Given this list of marker genes ATPAF2, TSPAN3, HLA-DPB1, ZSCAN32, RHOB, OPN3, COQ2, USP22, SHMT2, HSP90B1, FBXW11, LMO2, CAT, CD200, TULP2, PDE7B, SPIB, S100A8, TBC1D9, TSHR, COBLL1, RAB31, TBC1D22A, FTSJ1, MKLN1, ZDHHC4, NT5E, SYPL1, SCRN1, CNP, MICALL1, FCGR2C, METTL25B, CLEC4A, IGKC, RASGRP3, ISG20, IGHM, LAMP5, HPS5, PIP5K1B, ARMCX2, CTSH, ZNF804A (NCBI Gene Id 91752), PSMD10, GSTZ1, SAV1, MS4A1, ATP10D, NUMB, HLA-DOB, IRF4, EIF2AK3, COPB2, FCGR2B, HLA-DRB1, SLC15A3, CD1C, HK2, PCDH9, BACH2, SYT17, B9D2, PAX5, BASP1, SEC14L1 (SEC14 like lipid binding 1), ADRB1, H2AC6, TMEM156, LAT2, BCL11A, SIDT2, TMEM62, SWAP70, PUS1, IRF7, ZBTB18, SEL1L3, PPP1R16B, GNA12, TNFRSF17, EHD3, PECAM1, COX17, YBX3, FAM30A, RUFY1, ANXA4, GUCY2C, IGHD, IRAK1, HTRA2, MEF2C, IFNA6, PARM1, DUS2, SERPINA1, PDLIM1, RHOQ, CYBB, H2BC12, MAP3K9, MTSS1, FGR, ACP5, MAPK12, CKS2, MZB1, MMACHC, FA2H, DACT1, TRIB1, PSEN2, TCL1A, SQLE, JADE3, BHLHE41, RABGEF1, HARS2, H2BC9, ALOX5, TCF4, ALDH2, CACNA1A, DALRD3, OAS1, HLA-DMB (NCBI Gene Id 3109), ENSA, MAP3K8, BACE2, RASSF2, HHEX, IGHA1 (immunoglobulin heavy constant alpha 1), CSF2RB, AGPAT5, HS3ST1, SIDT1, BICRAL (BICRA like chromatin remodeling complex associated protein), TOP3B, TFEB, SAG, ZNF232, GUSBP11, P2RX5, TNFSF13 (NCBI Gene Id 8741), CHFR, KCNN4, ADA2, HLA-DRA, IRF8, ARPC3, FBXO41, TMUB2, BAIAP3, SEC23B, FCER2 (NCBI Gene Id 2208), CASC3, URB1, MRPL15, PAPSS1, CRIP1, CHST15, GALNT10, NT5C, TST, CLMN, PSAP, E2F5 (NCBI Gene Id 1875), LYL1, HDDC2, CD14, BMP2K, TMEM70, SNN, AMPD3, CKAP4, DGLUCY, CDKN1A, PKIG, TOR3A, ADK (NCBI Gene Id 132), TRIB3, TUBB6, UROD (NCBI Gene Id 7389), HLA-DMA, SLIRP, ADO, CHKA, DHRS7B, EMC8, BANK1, CA2, C5orf22 (chromosome 5 open reading frame 22), PLEK, BLCAP, ORC5, APOBEC3G, TERF2, here is a description of the gene set: from publication Jeffrey KL, Brummer T, Rolph MS, Liu SM, Callejas NA, Grumont RJ, Gillieron C, Mackay F, Grey S, Camps M, Rommel C, Gerondakis SD, Mackay CR (PMID 16474395) Genes up-regulated in comparison of B cells versus central memory CD4 T cells. Human Gene Set: GSE3982_BCELL_VS_CENT_MEMORY_CD4_TCELL_UP In the present study we used Affymetrix oligonucleotide microarrays to produce gene transcription profiles for the major leukocyte types in humans. This comprehensive dataset enabled us to not only establish which genes were expressed in each leukocyte type, but also which genes were expressed in each subset after activation. The used of a comprehensive dataset of gene profiles from all the major human leukocyte subsets enabled a novel and powerful means for identification of genes associated with single leukocyte subsets, or different immune paradigms. species: Homo sapiens